Given this list of marker genes NIPAL2, BTG2, EBPL, HINT2, GALC, PIP4K2A, NKIRAS1, C7orf50, TMEM116, FCER2, SLC39A6, NFKBIZ, MSI2, TMEM45B, SLC22A18, TEX264, ATP2A3, FES, HACD1, EPRS1, GNG7, RHOB, TSPAN32, GPX3, VWA8, GPR101, CTNNAL1, ALDH5A1, CCDC85B, SIT1, HACD4, BMPER, VCL, HOXA5, MFNG, ARL5B, UBL7, SLC39A10, PTPN4, CCDC28A, TPRA1, WDR83, FADS1, CD1E, ZBTB20, PDZD11 (PDZ domain containing 11), EGR3, WNT2, NDUFAF6, RPL7A, GMCL1, PYCARD, CACYBP, BCAT2, MAN2A2, RPS3A, CBX7, LIF, KYAT1, VAMP8, TMT1A, BTD, PLBD1, GPD1L, TSPYL2, DNAJC12, ANKH, RAB34, RAP1GAP, ADK, CERK, NMNAT3, ZNF704, ADAM23, PTGS1 (NCBI Gene Id 5742), AK2, ZNF789, FAM200B, EMB, HACD2, SIGIRR, MIF4GD, BCAS3, SLC46A3, EIF4EBP1, CLMN, QPRT, PAX2, KLRD1, ARHGDIG, ADORA2B, UQCR10, KHDC1L, CYB5R1, DCXR, ZC3H12A, PCM1 (NCBI Gene Id 5108), CFAP184, ABCD3, ARV1, EIF3L, REX1BD, CITED1, EID1, TBC1D5, IER3, SLC12A7, XYLT1, RPS17, RFC2, ALOX5, STAC2, FAM98C, ERICH1 (NCBI Gene Id 441310), NDUFB10, ADRB2, TRAPPC2L, BAIAP2-DT, PLEKHA6, SLC25A14, ZSWIM7 (zinc finger SWIM-type containing 7), ANO8, PLEK, DOCK1, PARVG, TM6SF1, IRGC, MPND (MPN domain containing), PGM2, HLA-DMB, NAA38, CYP1B1, PPP2R2B (protein phosphatase 2 regulatory subunit Bbeta), MAFF, GALNT13, CRTAP, OSR2, ZNF428, IDH2, CDIPT, SOST, PPP1R15A, ERI3, PPP1R7, EGR1, TMEM9, DNAI4, PECAM1, SPRING1, ABCC12, RNF39, SLC18A2, RRS1-DT, LCP2, CYP2A6, CCNE2, LTK, GALNT18, PRCP, PRAM1, PCYOX1 (NCBI Gene Id 63081), EPAS1, TP53INP1, STX19, CDR2L, CSF1R, VSIG4, STXBP1, PHYHD1, RPS4X (NCBI Gene Id 6191), HVCN1, PRADC1, EFHC1, MAT2A, SLC25A4, STX11, ZFP36L2, TREM2, NUP98, PEMT, JAG1, HSPA8, PON2, MXD4, SMTNL2, GKAP1, COMMD6, SLC12A9, ST8SIA2, TST, NME3, POLD1, IMPA2, NFATC1, CLEC4G, GSTT1, here is a description of the gene set: studied in species Homo sapiens Human Gene Set: GSE2706_2H_VS_8H_LPS_STIM_DC_UP Genes up-regulated in comparison of dendritic cells (DC) stimulated with LPS (TLR4 agonist) at 2 h versus DCs stimulated with LPS (TLR4 agonist) at 8 h. from publication Napolitani G, Rinaldi A, Bertoni F, Sallusto F, Lanzavecchia A (PMID 15995707) Toll like receptors (TLRs) sense microbial products and initiate adaptive immune responses by activating dendritic cells (DCs). Since pathogens may contain several agonists we asked whether different TLRs may synergize in DC activation. We report that in human and mouse DC TLR3 or TLR4 potently synergize with TLR7, TLR8 or TLR9 in the induction of selected cytokine genes. Upon synergistic stimulation, IL-12, IL-23 and Delta-4 are induced at levels 50-100 fold higher than those induced by optimal concentrations of single agonists, leading to enhanced and sustained TH1 polarizing capacity. Using microarray analysis we show that only 1.5% of the transcripts induced by single TLR agonists are synergistically regulated by combinations of TLR4 and TLR8 agonists. These results identify a combinatorial code by which DCs discriminate pathogens and provide (suggest) a rationale to design adjuvants for TH1 responses. Series_overall_design: 3 untreated, 3 treated with LPS at 2h, 3 treated with LPS at 8h, 3 treated with R848 at 2h, 3 treated with R848 at 8h, 3 treated with LPS + R848 at 2h, 3 treated with LPS + R848 at 8h